Given this list of marker genes MTMR14, CHD8, F3, RNF214, RMND5A, TTLL13 (NCBI Gene Id 440307), ELOVL1, COG2, PDIK1L (PDLIM1 interacting kinase 1 like), SPTLC2, OSBP, CCDC9, POLG-DT, JMJD1C, RPL30, LNCOC1, NGEF, CRIPTOP2, RAB4B, SNORD42B, UFD1, SYS1-DBNDD2, CNOT9, TRIM23, GNG3, SYN1, CHST11, ISG20, ZNF410, SELENOH, EPB41L4A-AS1, SRP54-AS1, PCDH9-AS3, MAP7D1, ENSG00000232995, ACOT9, LINC02354, TLCD2, CHMP4A, ENTPD6, PSMD8, MIR548AW, PEMT, PDXDC2P-NPIPB14P, FARS2, ISLR2, SYNCRIP, CCAR2, MARF1, SNORD68, ITFG2, CIAO2B, SOX12, FUZ, TYMSOS, CAPN6, RNVU1-28, PTOV1-AS1, ZNF317, MRE11, SAMM50, SBDS, LGMN, RNA5SP354, GTF3C2, DDX11-AS1, VSIG10L-AS1 (NCBI Gene Id 118827807), MAP3K9, FASTK, GALNT10, RNU5F-1, GRPEL2, CWF19L2, RBBP6, RNVU1-2A, TTC9C, PNN, GFI1B, LINC02614, MLEC, PRDX2, CLN8, NUDT16, TOGARAM1, INAVA, RPL23AP53, CSNK1A1, TRIM8, BTBD8, NDC80, FAM133B, SUCLA2, FCHSD2, LRSAM1, MCM4, ZBTB25, PCNX4, MIR378D2HG, ZDHHC2, FAM156A, TFEB, STUB1, GARNL3, NUMA1, TSPAN1, MEMO1, LIPT1 (NCBI Gene Id 51601), ELP3, MRPL45P2, EIF2D, TRIAP1, MRPL46, AKAP3, DPM1, EIF4G3, LINC03044, ZC3H10, DDX19B, PCSK4, ADPRS, CDK2AP2, MROH8 (maestro heat like repeat family member 8), RAP2B, LINC02112, POLR1G, ZNF45, NDUFAF1, SETD5, MAGOHB, ZNF821, CCND1, AASDHPPT, NFIC, ZNF565, ZNF3, FBXO33, LINC00881, PRKAG2, DNMT1, TOR1AIP1, RNVU1-14, TSFM, SNX8, SUGT1, MCM7, IDI1, RGS5, RBPJ, PHF1, LRRC47, HDLBP, SUPT4H1, TBC1D23, MEAK7, CTU1, ATP6V1C1, GPS2, MIB1 (MIB E3 ubiquitin protein ligase 1), LRFN5-DT, KMT2C, DKK1, STAT5A, FRAT2, PDXDC1, PTGER4 (NCBI Gene Id 5734), SYAP1, RSPH3, LANCL2, STAG3L2, SF3B6, TP73, CNOT6 (CCR4-NOT transcription complex subunit 6), FABP3, SCAMP3, ZNF101 (NCBI Gene Id 94039), COX18, CENPP, ESR2, ENPP2, TRAPPC13, EPN1, AKAP1, MANBA, NDUFB5, KAZALD1 (NCBI Gene Id 81621, Kazal type serine peptidase inhibitor domain 1), PPP1CA, SLC19A2, TCF12, XXYLT1, FAM110A, POC1A, PPP1R3F, FAM86C1P, FAIM2, DDX54, TMBIM1, ZNF131, BCL7B, PLS1, PEF1-AS1, CEP95, PTK6, SLC25A45, HMGCR, FSTL3, VPS8, ONECUT3, DUSP23, GLCCI1, SRP14-DT (SRP14 divergent transcript), HMGB1, GASK1B, PHKA2, RNASEK, KRT7-AS, SNHG29, PHLDB1, ANKMY2, BORCS7-ASMT, SLC12A2-DT, TPM1, ZNF761, FAM162A, MTERF3, TMX2, DOT1L, H2AC21, GPI, XKR6, DNM1, GTF3C3, ANP32E, POLG2 (DNA polymerase gamma 2, accessory subunit, NCBI Gene Id 11232), TENM3, DBT, RPL38, EEF2K, TTLL7 (NCBI Gene Id 79739), NBPF12, DGAT2-DT, FBLN1, MOB4, EEF1D, YY1AP1, MORN2, SAC3D1, PMF1, DNAJC28, MRPL13, MCFD2, ZNF33B, CWC27, SMARCAL1, STEEP1, PQBP1, IFIH1, HNRNPL, TIMM21, TCAIM, IL6ST, RHBDD3 (NCBI Gene Id 25807), DDX59, MED19, CPE, DAP3, ITSN1, WDR37, PCNX4-DT, ACTB, CCDC14, KCNAB2, SEPTIN9, OPA3, CEP57L1, FYTTD1, RBM12, MIR5087, FRAT1, DNAAF3, TMEM203, PSMA6, PHRF1, ZFP91-CNTF, UBA1, ARHGEF37, ST7, KTN1-AS1, PMM1, TRIP4, ADGRV1, TRIM29, PAN2, NBPF1, H4C4, ECE1, KMT5A, SIN3A, NEU3, TRIP10, NAB1, ENSG00000233461, MIR3677HG, RNVU1-21, TAF8, HGSNAT, PPP5D1P, BCL2L13, HECTD4, FAM86DP, SLC44A1, LRP10, DMAP1, ELL, SIRT2, SEPTIN2, HTR5A, FAM20B, APTX, RPS28, LINC02926, FGFR1OP2, C21orf91, CCNA1, SPART, ALCAM, TUFT1 (tuftelin 1), ZNF513, TMOD3, CCZ1B, TSPAN10, STUB1-DT, FBXW7, ADGRF5, SP1, HMOX2, ERI2, MTCH1, GSE1, RBM23, PEF1 (penta-EF-hand domain containing 1), SASH1, TADA3, SLC26A6, ESRRG, PRDM10-DT, IER5L-AS1, KMT2E (lysine methyltransferase 2E (inactive)), SPATA7, GABPB2, REEP3, STAG3L3, TMEM18, SLC38A4-AS1, HYOU1, ENSG00000248187, H1-3, HMGA2-AS1, EED, GHR, MED26, AFF1, C11orf68, DZIP3, OPA1, TNFRSF10A-DT, HACD2, SPTBN5, TMEM19, SEPTIN6, STX16-NPEPL1, DHRS9, PI4KA, VILL, SEPTIN4-AS1, MIR210HG, CSNK1D, PNISR (PNN interacting serine and arginine rich protein), ATAD5, CRTC3-AS1, NECTIN3-AS1, ATXN2L, EMSY-DT, SESN1, PTCD2, TRIM69, TRAK1, CDKN2C, MYL6B-AS1, CHCHD1, STARD13, POLR2H, DLST, CHCHD2, EIF4ENIF1, FSIP1, RNU5E-4P, CCSAP, THAP7-AS1, CDK5, PPP6R1, TPM3P9 (tropomyosin 3 pseudogene 9), CDC42SE1, MAOA, UBP1, NXN, SRP54, HINT2, H4C11, ULK4, TREX1, MAGOH (NCBI Gene Id 4116), GLI3, UNC5B, PURA, SH3BGRL3, ENSG00000266401, RBFOX2, TRIP6, OXNAD1, TIGD5, SLC66A3, RPS6KA4, NCAPD3, CHMP3, ADRA1D, CEP72, SUCLA2-AS1, CCDC88B, TUT7, SIX2, SMC1A, IFI16, CYTH1, MMP25-AS1, MBNL1, CFAP96, SS18L1, RERE, EEF1A1P23, POGZ, SPAG5-AS1, ATP6V0C, IBA57, PIF1, LINC00869, CPSF2, RAET1K, MIR4733, RCL1, LARP4, MNT, AMIGO3, NBEAL1, AGBL5-AS1, CIZ1, NDUFA9, MAF, DCUN1D3, GCA, SNORD104, RHOF, RPL23A, CDCA7L, NDOR1, TBCCD1, ZNF846, TYW1, EXOSC5, NRSN2-AS1, ALDH4A1, NBPF11, CENPE, CDKL3, AP4M1, DOCK8, RNF123, SNAP29, TMEM243, USF1, LINC02934, BTAF1, BAZ2A, SMARCD2, CD9, H2BC17, APMAP, ARRDC1, NBL1, CSTB, ZNF774, DPH3, PRKCE, MFSD4B-DT, MYLK-AS1, CAGE1, SLC39A6, RNU2-17P, STX5-DT, C6orf62, BOLA1, GGA1, FER, USP3, RAI14, ZNF449 (zinc finger protein 449), SLC25A28, S100A10, PMF1-BGLAP, CIRBP, SYT7 (synaptotagmin 7), RNU4-2, ZCCHC24, NECAB3, AHI1-DT, PRR3, ENSG00000273162, MCTP2, TENM3-AS1, PTPRG, PCLAF, ARHGAP11B-DT, COPS8-DT, ZBTB22, NR1H3, MADD (NCBI Gene Id 8567), SYVN1, ZNF470-DT, RNFT1, MYL12A, BZW2, ACIN1, RALY, RSL1D1-DT, WAS, TMEM263, SERP1, LSG1, RPL12, CUL2, RARG, PLXNA3, PHIP, SFR1, TAX1BP1-AS1, HNRNPH3, MYD88, MDM2, RNF213-AS1, POC1B-AS1, WDR13, CREB1, MBOAT7, PRDM10, BUD13-DT, STN1, PPFIBP1, ATP6V0E1, NMRAL1, LINC01560, SLFN5, PPP1R13L, C18orf32, PRLR, ELF1, NT5DC3, MYG1, S100A4, THEM6, SYS1, RACK1, GATAD2A, TXLNA, SLC22A4, DENND2B, KBTBD11-OT1, CEP55, FRMD6, PCBP2, FCRLA, EIF1B-AS1, POLR1B, H3C12, BLM, BBIP1, H2BC21, GGPS1, POLR2L, CFB, DDIAS, BLOC1S6, RTKN2, PAICS, RNPS1, UQCR10, NUF2, GSPT1, CHPF, HADHB, EIF2AK3-DT, POU2F1, UBE2D3, POLR3E, LPXN, SGK1, IER3-AS1, DDX5, PDPR2P, TPRA1, RALA, TP53I3, IBA57-DT, FLOT1, CHRAC1, MIA2-AS1, TUBB4BP7, UFSP2, DAW1, TIRAP-AS1, UBA3, WASF1, PSMD7, PRMT1, EIF2AK4, NDUFB2 (NCBI Gene Id 4708), PIGL, GINS2, GABARAPL1, CATSPERG, RNA5SP40, RNU5E-1, JUN-DT, TFE3, BCL2L12, YWHAQ, FUT8, KLHL28, PTEN, PIK3CB, R3HCC1L, KIAA2013, PGM3, ZNF552, MAT2A, PRKCA, UROS, CCNB3, NUDT9, SYNE1, RANBP10, C8orf82, ANKRD13A, ELAVL1, AKIRIN1, HNRNPUL2-BSCL2, IDH1, CCND2, TMEM131 (NCBI Gene Id 55369), CELSR3, KANSL3, MTO1, PIK3R1, SPATA2L, SNORD118, PJA2, PCSK7, SNORD49A, IFT74, CPNE1, MYL12B, ADD3-AS1, COMTD1, EMG1 (EMG1 N1-specific pseudouridine methyltransferase), RNU11, DMXL1-DT, SELENOW, RN7SL473P, ZNF564, RSL1D1, UBE2A, ASH1L, C10orf143, PRRT2 (proline rich transmembrane protein 2, NCBI Gene Id 81865), ZNF609, SREK1IP1, RPS6, MITD1, FCHO1, IFT52, ATG12, PYGO2-AS1, THAP7, MICOS10-NBL1, R3HCC1, MAST4, PIP4K2B, HNRNPUL1, CFAP221, NABP2, TCAM1P, VWA7, TMEM198, IST1, SLC25A16, ARRB2, ESYT2, ZNF286B, DNAJB11, NLGN2, TRIQK, RPRD1B, SLC27A5, RPL39, TMEM40, PA2G4, ASAH1, COQ8B, LINC02896, PCDH7, SPATA24, PCYOX1L, BLNK, INKA2-AS1, ACD, GRAMD2B, MTPN, SNORD13, ATF7-NPFF, ZNF765, COX20, ARMH3, ZDHHC9, FAM161B (FAM161 centrosomal protein B), MAP3K14, ARPC5L (actin related protein 2/3 complex subunit 5 like), QPCTL, HEY1, CCDC88A, SCNN1A, CDT1, LIN54, MBNL3, RNVU1-2, EXOSC6, MFSD4B, SPIN1, RAB14, E2F6, ARID4B, CATSPER1, PYGO2, KBTBD3, TAF9, CXXC5, UQCRH, KANSL1, SLBP, TCP11L2, TPBG, AAGAB, SPRED2, UCHL3, NUMBL, MIR4757, SNORA50C, ENSG00000236098, TSPAN4, FUS, H2AC20, CDIPTOSP, JUN, CASP8, C6orf226, CDIPT, GALE, SSRP1, AKT1S1, AK2, AK1, GOLGA3, MIR130AHG, DNAAF9, MTNAP1, COMMD6, PKNOX1, IFRD1, ETV2, TSGA10, PTOV1, AP3S1, PGGT1B, TSC22D2, FBLN2, WASHC2A, MIR7-3HG, SRPK1, IL23A, LINC01775, SPA17, MAP3K14-AS1, CALR3, MCRIP2, BNIP1, CUL9, COQ10B, ALG13, ZNF219, GRIPAP1, CHD6, MBTD1, MDK, ITGB3BP, CFAP68, RNASEH2C, ZNF146, NCOA2, GRPEL2-AS1, ZNF639, COPS5, DCAF8, CLN8-AS1, SMC3, PKM, RNU5A-1, BRF2, C19orf25, RNVU1-27, ZNF286A, UPP1, LINC02453, C19orf44, BLTP2, ATP5MG, STX16, CREBRF, FAM83E, RUBCN, TM9SF2, SUGT1-DT, EIF3B, MIR7-3, SNORA13, TMEM260, LINC00882 (long intergenic non-protein coding RNA 882), RPS17 (ribosomal protein S17), CD109 (CD109 molecule), RGS9, PTP4A2, ADAMTS6, DNAJA1, PLXNA2, COPS4, GDF5, NUDT16-DT, FAM53C, UQCRBP2, ATP8A1, DUBR, MYL6 (NCBI Gene Id 4637), BCL9, PPIA, TWF1, ADGRG1, ARHGEF17, NBDY, WDR44, RPL22, NT5C3A, RPA3, CNOT10, DHX57, DRG2, POLDIP3, RNVU1-15, FAM157A, SPAG5, WRAP53, MTDH, DRAP1, LINC02236, EBAG9, ARHGAP42-AS1, CEP250, TMEM9B, NKAP, THBS1, WDR12, MEIS2, TJP3, ZNF815P, WDR36, CPEB4, MSH4, GPR173, SHC4, AKAP8L, TACO1, EMC3, JRKL, MIR3189, SS18, IRF3, ATF7, KIAA0586 (NCBI Gene Id 9786), HIGD2B, GNB2, HAUS8, HERC4, ST7-OT4, NPB, USE1, PIKFYVE, LINC01607, MYORG, UFL1-AS1, WDR5-DT, ZNF282, RGL1, ALG1, SLC35E2A, AHI1, TM7SF2, ACKR2, SYTL1, INPP5K, STAP2, ANXA9, ENSG00000273727, SNRPD2, FKBP8, NFKBID, CHID1, CPSF3, TMEM170A, WASL (NCBI Gene Id 8976), TSNAX-DISC1, PSMB9, ACACB, C14orf93, DLGAP5, SMG1-DT, H2BC6, SLC41A2 (NCBI Gene Id 84102), CCT5, CALM3, PLPP6 (NCBI Gene Id 403313), CEP63, TSNAXIP1, VPS37C, DDAH2, UFL1, WASF2, SRXN1, DMXL1, SCRIB, PISD, MAP3K9-DT, IFT122, KCNIP2-AS1, MYT1, VPS72, RMND5B, SLC25A26, NUDCD1, ZNF286A-TBC1D26, ZNF263, FAM21EP, EHD2, LIPE, CFAP298, MIR4530, RTN4, MRPL30, AARS1, CYP51A1, SHANK2, SLFN12, RARA, SLC12A2, TM4SF1-AS1, DCAF11, SLC35F2, RAB3A, ALKBH5, GPR108, LYRM4, LRCH4, SLC25A19, YJU2, RAB28, ANKRD17, PRRT1, ZBTB12, PLXNB1, PARD6A, DRAIC, RBIS, FBXO24, DZIP1L, PDE4DIP, XDH, SUCO, PLCD3, RIBC1, PRPF40A, USP15, BCL6, NOCT, SLC46A2-AS1, TMEM253, QRICH1, ZNF865, MAGOH-DT, CHMP2A, TMEM198B, CCDC85C, EIF2A, MIR9-2HG, MSTO2P, STK35, MTAP, CENPJ, FAM86FP, MAGIX (NCBI Gene Id 79917), RTN4RL2, ACP6, RFX5, FLCN, ARPC4-TTLL3, RPS6KC1, MECOM, LINC01719, PTCD3, POLD1, SNORD95, NPAT, SMAGP, COL9A3, HSPA1A, RUSC2, RPS27, TJP2, ZNF41 (NCBI Gene Id 7592), FCHO2, WDR18, CLN6, CEP192, COTL1, RNU12, LINC00870, NBPF3, VDR (NCBI Gene Id 7421), TSLP, CDC7, ROBO4 (roundabout guidance receptor 4), RPL35, GTF3C2-AS2, RNVU1-34, RNVU1-24, SOD1-DT, HSPA1L, PRKG1-AS1, RAVER1, CTSB, EEF1A1, PRCP, LUARIS, ZNF470, AQP7, PARK7, MRPS24, CDH26, CENPN, LATS2, PHLDB2, ATP6V1H, CTNNBIP1, IRF2BP1, ANXA8, ABLIM1, ATG16L2, INKA2, KTN1, VSIG10L, RABEPK, MOCS3, SLC7A8, GAS7, PIPOX, SEMA6A, PSIP1, SGO2, HSPA1B, WASH3P, PPT2-EGFL8, PIP5K1A, MMP14, SLC35B2, AKT2, HAPSTR1, TACC1, NUS1, ZSCAN16-AS1, TTC7A, HSPA8, MRPL12, MCL1, ELP2, ZFAND3, C8orf74, MBD4, TRAF4, DUT, POLR1A, TAGLN2, DNAJC5, PPAT, ABHD16A, TSC1, BTBD10, HNRNPUL2, STARD3NL, NFKBIB, EIF4A1, SNHG25, RPLP0P2, RITA1, FAM182B, ARID1A (AT-rich interaction domain 1A), CCDC82, KDM4C, MED15, MAPK11, TSG101, STAT2, KDSR, LINC02029, POM121C, OGG1, ZNF451-AS1, RAD17 (NCBI Gene Id 5884), TXNDC17, AK6, CAPS2, AMOTL2, BORCS7, RUSC1-AS1, NECTIN3, HDAC2-AS2, SAR1B, SHROOM1, ENDOV, EPHB2, JMJD7, ATF6-DT, ATPSCKMT, PAXIP1-DT, TNFRSF10A, IFT46, HMGCL, GFPT2, ZNF600, ARF4, OTUB1, CASZ1, PRKDC, PADI1, LSR, OIP5-AS1 (OIP5 antisense RNA 1), CITED1, EDC4, SSR3, LPAR5, AKAP1-DT, MGRN1, SLC41A3 (NCBI Gene Id 54946), VPS26B, RNF14, SIAE, TPX2, DIS3L, TSEN34, MYO9B, SLC22A5, CDK13, LINC00910, ZNF518A, PLEKHB2, ACAA1, TMEM87A, POLR2A, HAP1, CSMD2, GNAS, HELLS, GNL1, SAP30BP, SGO1, TMEM250, UBR2, ENO3, CFAP36, CLCA2, MRPL53, ARPC5, ARPC4, SUZ12P1, WDR5, RPL13, RNVU1-26, PTPRE, TSNAX, BBS4, POLG, GEMIN2, BRAT1, ZNF383, CDON, B3GALT6, ENSG00000187951, DOHH, ANAPC13, ANKRD36, TAF12, ENY2, ARHGAP27, MIR210, OXR1, ZFAND3-DT, TVP23B, FABP5P3, MICALL1, UIMC1, RPL19, MORN5, CDC40, SCG5, PPM1L-DT, SPATA17, GDF9, TFAP2A-AS1, GLMN, AGBL5, PKIA, SSB, ACP2, CIC, CSTA, SNRNP35, FMC1-LUC7L2, PRDM1 (NCBI Gene Id 639), LRRC14, ZNF300, GSTO2, BCAR3 (BCAR3 adaptor protein, NSP family member), MIB2, TCF4, MFN1, PLEKHG5, LTBP4, TAF15, GIPC1 (GIPC PDZ domain containing family member 1), UBB, KRT7, FAM43A, ZNF638, UTP18, SIDT2, DISP3, CRY1, PPM1L, THOC6 (THO complex subunit 6), KCTD2, CDV3, RAB4B-EGLN2, GPAT4-AS1, DPP9, REEP6, MIR100HG, SETDB2, SCARB1, RNU5D-1, PCGF1, CSPP1, OXR1-AS1, PRKRIP1, NF1, SNRNP70, TMEM219, PRKCI, FAM86JP, FAM229B, WDR73, XKR4-AS1, BCCIP, MLLT6, SLC5A6, WDR4, ARL6IP6, IQCH, H4C3, GASK1B-AS1, NOLC1, NRM, BSCL2, GOLM2 (golgi membrane protein 2), TMEM9B-AS1, SGO1-AS1, ZNF33A, GDF15, FOS, MICB, LYRM1, ZBTB1, LIPE-AS1, POLB, INO80D-AS1 (INO80D antisense RNA 1), PMVK, HEXIM1, MDP1, PON2, UCN2, SLC35E2B, POR, ORMDL1, POLI, KGD4, ROBO1, SLC3A2, KRT86, MRPS11, CD164, TBC1D17, GATC, TENT2, NDST2, TMT1B, TWNK, RIT1, ZNF277, GPATCH2, VPS45, TYMS, PSMD7-DT, PDE2A, UCKL1, SPRY2 (NCBI Gene Id 10253), FANCI, MSX1, CLASP1, CBY1, INO80C, PAPPA-AS2, PTDSS1, SHISA4, NANOS3, ZFP91, IFT70B, SLC39A1, CDC45, RNVU1-31, EPG5, FZR1, PHF12, DVL2 (NCBI Gene Id 1856), TNK2, ZNF30, MARCHF10, JMJD4, ADGRL1, MICAL3, BBLN, IER2, TARS2, CFAP298-TCP10L, EPS15, TENT5B, CDK13-DT, ERCC6L2, CXCL8, FBXL14, NDUFV3, INTS13, CCDC171, MAD1L1, MEIS1, EIF2AK3, FIRRE, LRRC41, ESYT1 (NCBI Gene Id 23344), CPEB3, ANKRD10, ERCC5, CALD1, PHF11, SEPTIN11, ATG101, TOX4, CDK16, NUP43, ADNP, FOSL1, TLR3, TARDBP, MED18, EEF2KMT, ATM, GANC, PAFAH1B3, CFAP418, KIAA0753, SPIN2B, MYL12-AS1, SCUBE1-AS1, GNAL, WDR5B, MAST4-AS1, FBXO15, ENSG00000239137, HADHA, ATP8A1-DT, RPLP1, GPAT4, GBA1LP, ATP13A4, CFAP77, PFDN4, PRMT5-AS1, RNASEK-C17orf49, MIR1289-1, MIX23 (NCBI Gene Id 131076), EIF1, EID1, GAS5-AS1, TAFA2, UQCRC2, TNC, MYOSLID-AS1 (MYOSLID antisense RNA 1), CYP51A1-AS1, UBE2B, WDR24, TPRKB, MEIS1-AS3, HDAC2, GPR180, LINC02585, CENPU, TBK1, ATP5F1E, TUBE1, GCLC, PPIB, SIGMAR1, PACSIN2, ATG7, ATRNL1, CNIH2, H1-4, CA13, ZNF75D, VBP1, HYAL2, SOCS5, PNPLA6, RNASEH2B, INTS10, TIMM9, SMG1, FAM227A, CD151, WWOX, CALCOCO1, SRI, RAD23A, MICOS10, JUP, CRYZL1, MAT1A, STT3B, HINT3, PSMA7, RNVU1-30, PDXDC2P, CUL4B, TTI2, NDE1, PHB2, REXO2, CSNK2A1, MPND, MPHOSPH6, AKR1A1, DUS4L, AHNAK, TAP1, CLCN2, ZNF30-AS1, ZNF584, N4BP1, SOD1, PTGR1, BZW1, PPFIA3, MTBP, RAB10, LINC01852, ITGB1BP1, HSD17B8, PPOX, GRIP1 (NCBI Gene Id 23426), COPS8, ZNF225-AS1, CAPN10, C5orf15, SDF4, TACC3, PMS1, SPRY4, CNNM2, ZNF703, JMJD7-PLA2G4B, ERCC6L2-AS1, BCKDHA, DAXX, THUMPD3-AS1, DNAJC14, CCND3, SNORD49B, GET3, PRRC2A, ELAVL2, TBX3, MIA3, C5orf34, EGLN2, ASAH1-AS1, UQCRQ, STRIP2, SLC6A15, TBC1D12, NDUFB8, ZNF845, EPHX1, CACNB3, UBAC2, NDUFV2-AS1, FAM228B, SP3, PICALM, ATRAID, ASPM, ARFRP1, ZDHHC5, ZNF311, FRMD5, RAB26 (NCBI Gene Id 25837), NR6A1, FAM185A, ANKRD12 (NCBI Gene Id 55606), MLST8, GRB7, MIA2, TAX1BP1, ANO10, RPN2, RNFT1-DT, CES2, TM4SF1, ETNK1-DT, KLHL22, DRAM1, LRPPRC, SRPK2, TIMM17B, CEP72-DT, MYH9, RFX7, KRT5, SHARPIN, BUD13, HAGHL, NOL8, VCF1 (VCP nuclear cofactor family member 1), TAS2R1, TMEM256-PLSCR3, RNVU1-6 (RNA, variant U1 small nuclear 6), MAN2A2, NDUFA6-DT, MRPL43, BICD1-AS1, EMC3-AS1, ITPRIPL2, GPATCH3, PPT2 (palmitoyl-protein thioesterase 2), ADRM1 (ADRM1 26S proteasome ubiquitin receptor), NDUFA6, DDX11, CIP2A, TCEA1, PAXIP1, LGALS1, TOM1L1, LINC02018, LNPEP, DUT-AS1, RNVU1-22, PNMA1, TMEM256, EIF1B, RUSC1, DOCK4, LRATD2, GSEC, FCHO2-DT, MED24, NOP56, SNAP47, CYREN (cell cycle regulator of NHEJ), CBLL1, NFXL1, CMC2, B3GALT4 (beta-1,3-galactosyltransferase 4), RWDD2A (RWD domain containing 2A), C10orf88B, WASL-DT, DTWD2, MIR583, UGGT2, SHOC2, NFKB2 (NCBI Gene Id 4791), LINC01315, SMARCAL1-AS1, USP37, ATP5PD, MEIG1, ZNF514, SGK3, PDP1, TOB2 (NCBI Gene Id 51445), ITFG2-AS1, TMEM230, ZNF274, WDR5B-DT, CCNT2, FUT10, GALT, ACOX2, ARAP1, PER2, SECISBP2, SCO1, DGAT2, MRPS27, RPS24, ADSL, DIAPH1, OGA, DUSP7, ALPK2, MTMR4, EWSR1, NDUFB1, WTAP, RIOK1, PIK3R3, FAM120C, SREK1, HDAC1, PLEKHA8, FOSL2, COQ6, CREB3L4, here is a description of the gene set: Genes containing one or more binding sites for (BRCA2) in their promoter regions (TSS -1000,+100 bp) as identified by GTRD version 20.06 ChIP-seq harmonization. species: Homo sapiens from publication Yevshin I, Sharipov R, Kolmykov S, Kondrakhin Y, Kolpakov F (PMID 30445619) Human Gene Set: BRCA2_TARGET_GENES